Given this list of marker genes Adgrl3, Pank1, Rnf139, Chd9, Esrrg, Hspd1, Nedd4l, Satb2, Bcl2l11, Igf2r, Pcdh10, Rabgap1l, Ppp1r14c, Irx4, Rbfox1 (RNA binding protein, fox-1 homolog (C. elegans) 1), Zdhhc17, Atp2a2, Smim36, Stk39, Tmeff1 (transmembrane protein with EGF-like and two follistatin-like domains 1), Ano4, Cdh13, Gja1, Cpeb3, here is a description of the gene set: from publication Ikeda S, He A, Kong SW, Lu J, Bejar R, Bodyak N, Lee KH, Ma Q, Kang PM, Golub TR, Pu WT (PMID 19188439) Mouse Gene Set: IKEDA_MIR30_TARGETS_DN Calcium signaling is a central regulator of cardiomyocyte growth and function. Calmodulin is a critical mediator of calcium signals. Because the amount of calmodulin within cardiomyocytes is limiting, the precise control of calmodulin expression is important for the regulation of calcium signaling. In this study, we show for the first time that calmodulin levels are regulated posttranscriptionally in heart failure. The cardiomyocyte-restricted microRNA miR-1 inhibited the translation of calmodulin-encoding mRNAs via highly conserved target sites within their 3' untranslated regions. In keeping with its effect on calmodulin expression, miR-1 downregulated calcium-calmodulin signaling through calcineurin to NFAT. miR-1 also negatively regulated the expression of Mef2a and Gata4, key transcription factors that mediate calcium-dependent changes in gene expression. Consistent with the downregulation of these hypertrophy-associated genes, miR-1 attenuated cardiomyocyte hypertrophy in cultured neonatal rat cardiomyocytes and in the intact adult heart. Our data indicate that miR-1 regulates cardiomyocyte growth responses by negatively regulating the calcium signaling components calmodulin, Mef2a, and Gata4. Genes down-regulated in hypertrophic hearts (due to expression of constitutively active form of PPP3CA) and predicted to be targets of miR-30 microRNA. species: Mus musculus